Given this list of marker genes Nin, Zeb2, Bhlhe22, Prdm8, Pafah1b1, Grcc10, Tsku (NCBI Gene Id 244152), Szt2, here is a description of the gene set: Mouse Gene Set: GOBP_CORPUS_CALLOSUM_MORPHOGENESIS The process in which the anatomical structures of the corpus callosum are generated and organized. The corpus callosum is a thick bundle of nerve fibers comprising a commissural plate connecting the two cerebral hemispheres. It consists of contralateral axon projections that provides communications between the right and left cerebral hemispheres. species: Mus musculus